Given this list of marker genes Bmpr2, Dspp, Ccn3, Bmpr1b, Smad7, here is a description of the gene set: Mouse Gene Set: GOBP_NEGATIVE_REGULATION_OF_CHONDROCYTE_PROLIFERATION species: Mus musculus Any process that stops, prevents, or reduces the frequency, rate or extent of the multiplication or reproduction of chondrocytes by cell division, resulting in the expansion of their population. A chondrocyte is a polymorphic cell that forms cartilage.